The following is a description of a gene set: Genes predicted to be targets of miRBase v22 microRNA hsa-miR-676-5p in miRDB v6.0 with MirTarget v4 prediction scores > 80 (high confidence targets). from publication Chen Y, Wang X (PMID 31504780) studied in species Homo sapiens Human Gene Set: MIR676_5P, and this is the list of marker genes: SBSPON, RAD51B, CLDN12, ATF7, UBLCP1, TBC1D23, RALGAPB, SUZ12, RDX, FASTKD1, VAMP3 (NCBI Gene Id 9341), MTDH, LRATD2, DR1, CDH9, PRKACB, H2AZ2, GFPT1, FIGNL1, GRK3, DAZ1, MAGEH1, COL11A1, RBMS3, PCMTD1, THYN1, UGCG, DCAF6, NAP1L1, AJAP1 (adherens junctions associated protein 1), VSX1, MYBPC1, IPO7, GRIA2, MMP8, HEYL, LRRN1, GOLGA3, DAZ3, NPAT, TEX10, CAMTA1, ABHD18, REST, HNMT, FAM131B, TDRD15, OPHN1, HGF, RSBN1, LINC03043, LARP4, EML4, LAMA4, DDX17 (DEAD-box helicase 17), MORF4L1, PTK2, FCAR, GRM5, THAP1, RNF145, NCAM2, PDIA6, PTPDC1, GPATCH2L, FLRT1, FBLN5, EMC8, SRR, DAPK2 (death associated protein kinase 2), ITGA9, CDKN2C, IREB2, CCSER1, ELAVL2, RAB3C, SLC23A1, CREBRF, PTGER3, DISC1, EEF1E1, FYTTD1, PHF6, TOMM34, UQCR10, MKRN3, ARPP19, CD55, OOEP, PABIR3, WWC2, RPP30, TMCO1, FANK1, PRP4K, PRR13, NUP37, SRSF1, MATCAP2, MED29 (mediator complex subunit 29), TRAM2, FAR1, KCNMA1, ENTPD3, MORF4L2, PPTC7, CIDEA, COL22A1, TBL1XR1, RAPGEF2, CEP350, ARGLU1, EPHB3, TVP23B, HOPX, GJA1, GK, PPP4R2, MYO1E, NAP1L5, TPD52L2, CXCL2, FNDC3A, GOLT1B, EIF1AX, MRPL32, TMCC1 (NCBI Gene Id 23023), PLK2, NSUN7, ZNF737, ZFC3H1 (zinc finger C3H1-type containing), CNIH4, SGIP1, TNIP1, BCL7A, ST6GAL2, PIK3CA, MDM1, ZFPM2, CENPU (centromere protein U), CCER1, TMEM164, NLGN1, CCDC182, TAOK1, ARID4B, SCAF11, PCYOX1, AP1S3, GABRA4, DERL3, RTL3, CACNA1C, MAP4, CEP41, RND3, CCND2, MDM4